The following is a description of a gene set: species: Mus musculus Human Gene Set: BERENJENO_TRANSFORMED_BY_RHOA_FOREVER_DN We have used microarray technology to identify the transcriptional targets of Rho subfamily guanosine 5'-triphosphate (GTP)ases in NIH3T3 cells. This analysis indicated that murine fibroblasts transformed by these proteins show similar transcriptomal profiles. Functional annotation of the regulated genes indicate that Rho subfamily GTPases target a wide spectrum of functions, although loci encoding proteins linked to proliferation and DNA synthesis/transcription are upregulated preferentially. Rho proteins promote four main networks of interacting proteins nucleated around E2F, c-Jun, c-Myc and p53. Of those, E2F, c-Jun and c-Myc are essential for the maintenance of cell transformation. Inhibition of Rock, one of the main Rho GTPase targets, leads to small changes in the transcriptome of Rho-transformed cells. Rock inhibition decreases c-myc gene expression without affecting the E2F and c-Jun pathways. Loss-of-function studies demonstrate that c-Myc is important for the blockage of cell-contact inhibition rather than for promoting the proliferation of Rho-transformed cells. However, c-Myc overexpression does not bypass the inhibition of cell transformation induced by Rock blockage, indicating that c-Myc is essential, but not sufficient, for Rock-dependent transformation. These results reveal the complexity of the genetic program orchestrated by the Rho subfamily and pinpoint protein networks that mediate different aspects of the malignant phenotype of Rho-transformed cells. Genes down-regulated in NIH3T3 cells (fibroblasts) transfrormed by expression of constitutively active (Q63L) form of RHOA off plasmid vector; their expression did NOT reverted completely after treatment with Y27632, an inhibitor of ROCK proteins. from publication Berenjeno IM, Núñez F, Bustelo XR (PMID 17213802), and this is the list of marker genes: ANKRD1, FLNB, CHD1, EREG, HBEGF, PHLDA1, LRRFIP1, PTGS2, BNC1, TNK2, HSPH1, MGP, ECT2, MTMR10, NPNT, POSTN, PLAUR (plasminogen activator, urokinase receptor), HASPIN, NOP58, F2R, EPHA2, ANXA3, GJA1, AMOT, CAVIN2, AKAP12, IER3, TOM1L1, CCDC80 (NCBI Gene Id 151887)